Given this list of marker genes NRP1 (neuropilin 1), FZD4, VEGFB (NCBI Gene Id 7423), DAB2IP, DLL1, FGF18, ROBO1, FGF10, MIR200C, HIF1A, GRB10, ARNT, MMRN2, PDCD6, MT3, PRKD2, MIR1224, HIF1AN, ITGA5, ITGB3, EMILIN1, PTPN1, VTN, IL1B (NCBI Gene Id 3553), EPN2, MMRN1 (NCBI Gene Id 22915), NEDD4, HGS, MIR10B, FGF9, TMEM204, MIR10A, MIR296, HHEX, VEGFC, CADM4, PRKCB, here is a description of the gene set: Human Gene Set: GOBP_REGULATION_OF_VASCULAR_ENDOTHELIAL_GROWTH_FACTOR_RECEPTOR_SIGNALING_PATHWAY species: Homo sapiens Any process that modulates the frequency, rate or extent of vascular endothelial growth factor receptor signaling pathway activity.